Given this list of marker genes SLC26A4, SLC4A3, SLC26A11 (solute carrier family 26 member 11, NCBI Gene Id 65011), SLC4A10, SLC26A3, SLC4A2, SLC26A5, SLC4A9, SLC4A1, SLC26A7, SLC4A8, SLC26A6, here is a description of the gene set: Enables the transfer of a solute or solutes from one side of a membrane to the other according to the reaction: solute(in) + HCO3-(out) = solute(out) + HCO3-(in). Human Gene Set: GOMF_BICARBONATE_MONOATOMIC_ANION_ANTIPORTER_ACTIVITY studied in species Homo sapiens